Given this list of marker genes Prmt2, Gramd1a, Foxp3, Smad2, Irgm1, Atp4b, Cflar, Mup11, Mir182, Nos3, Abcb4, Bpi, Akap12, Xiap, Rarg, Trim12c, Ggt1, Map2k7, Fkrp, E2f1, Zfp747l1, Mir494, Defa22, Cd55b, Nfkbiz, Creb1, Aacs, Asns, Fas, Selenos, Fbxo3, F2r, Mir223, Defa26, Tgfbr2, Spp1, B2m, Cbl, Il10ra, Cyp26b1, Kdm6a, Mbd3, Trem2, Selenow, Wbp2, Slit3, Snhg20, Pik3ca, Pdcd1lg2, Scnn1a, Mup3, Esr2, Insig2, Mir181a-2, Dnm1l, Mir15a, Thbd, Ces1a, Scgb1a1, Pou4f1, Kdm3a, Abca1, Ppard (peroxisome proliferator activator receptor delta), Crebrf, Bdnf, Gpr83, Mir30d, Il36a, Defa3, Mir98, Brca1, Nfkbib, Safb, Mir125a, Pck1, Sphk2, Cebpb, Slco1b2, Skp2, Mir26a-1, Ccl19, Ass1, Zfp747, Fosl1, Pdcd4, Pak1, Fech, Zmiz1, Ifng, Erbin, Ptger4, Tnip2, Aldh1a2, Tead2, Ticam1, Trim5 (NCBI Gene Id 675296), Aqp1, Rhox13, Per1, Mef2c, Prkce, Ptgdr, Cdo1 (NCBI Gene Id 76278), Bmp4, Cd6, Mest (mesoderm specific transcript), Meiosin, Acer2, Fkbp4, Ccl21a, Ret, Parp1, Rpl27, Xrcc5, Lta, Agl, Slc12a3, T, Ppp1r9b, Kank2, Prpf8, Adcy5, Gba1, Plcg2 (NCBI Gene Id 234779), Tnfrsf11a, Slpi, Plaa, Osr1, Areg, Bmp6 (NCBI Gene Id 28108), Lep, Ucp2, Mif, Hmgb2, Trim63, Bad, Acsbg1, Sox30, Cyp27b1, Rnf4, Bcl2, Mdm2, Pparg, Ptger2, Ptgds, Lcor, Slc11a1, Adcy1 (adenylate cyclase 1), Mir26b, Ltf, Serpinf1, Cxcl15, Gbp6, Zfp366, Irak4, Gata2, Card9, Clock, Avp, Sva, Ang4 (NCBI Gene Id 328486), Abca3, Csf3, Brinp1, Axin2, Alad, Srarp, Hmga2, Nr2f2, Nfkb2, Acta1, Pdk4, Epha3, Bin1, Stap1, Aldh3a1, Brinp2, Cnp, Adcy3, Cfh, Mir511, Mapk1, Ptch1, Mn1, Ren1, Drd2, Tpcn2 (NCBI Gene Id 233979), Prkcb, Hes1, Ugt1a6b, Elk1, Map4k1 (mitogen-activated protein kinase kinase kinase kinase 1), Tnfaip3, Foxo1, Mir199a-1, Mbp, Irs1, Scn11a (NCBI Gene Id 24046), Add1, Mir467d, Arid1a, Uba5, Ube3a, Cdc73, Ptafr, Ccl27a, Calcr, Ccl19-ps3, Noct, Tnfrsf1b, Alox12 (NCBI Gene Id 11684), Pten, Tacr1, Cdkn1b (cyclin dependent kinase inhibitor 1B), Tbxas1, Lefty1, Scimp, Pdcd7, Gprin3, Igfbp2, Plscr3, Hoxb13, P2ry4, Mgst1, Ddit4, Arid5a, Selenof, Got1, Fbp1, Rps6ka3, Ezh2, Abcb1a, Gramd1b, Synj1, Ccl19-ps4, Mapk8, Fam210b, Mir107, S100a8 (NCBI Gene Id 99591), Phb2, Mir672, Irak1, Trim55, Gjb6 (NCBI Gene Id 52881), Cyp7a1, Mir24-1 (NCBI Gene Id 387184), Nr1h4, Cxcl2, Gstcd, Bcl10, Mir202, Shq1, Hand2, Stc1, Vdr, Abr, Esrrg, Mup5, Irf3, Igkj1, Zbtb7a, Gnas, Alas1, Ccdc62, Slc39a9, Abl1, Socs2, Gnrh1, Postn, Gsk3b, Atp1a2, Cpn1, Cxcl10, Ptgir, Tnfsf4, Nr1h3, Pik3r1, Ly96 (NCBI Gene Id 17087), Ptges3, Hspa8, Mir184, Trim30a, Cdk19, Safb2, Tlr9, Pou5f1, Ctsl, Gfer, Ddx17, Acod1, Ptgfr, Hoxd13, Il1b, Irak3, C2, Tnip3, Git1, Rnf14, Mir381, Mgarp, Th, Kl, Mpo, Npas4, Mir7-2, Tlr4, Bdkrb1, Rest, Bckdhb, Otud5, Sox10, Lats1, Jund, Hoxa13, Efnb2, Cited1, Sst, Ltk, Tab2, Mup2 (major urinary protein 2), Defa29, Mir181b-2, Sstr3, Lias, Sult1a1, Hnrnpd, Bcr, Gpr155, Gjb2, Atp5f1a, Tlr2, Tfap2a, Ccl19-ps1, Ces1f, Mir7-1, Ovca2, Adam17, Yes1, Pax2, Havcr1, Cx3cr1, A2m, Ar, Adm, Mir142, Sirpa, mt-Nd3, Mapk14, Htr5a, Ffar3, Defa30, Aard, Ptk6, Lbp, Nr2c2, Adam15, Stat5b, Cry2, Crls1, Cdkn2d, Smarca4, Esrrb, Tbx2, Cad, Scd4, Ntrk2, Maob, Cd180, Mir30c-2, Ccl21d, Wnt7a, Sgk1, Ednrb, Cyp19a1, Adra1b, Nfkbil1, Nlrc3, Map7, Cnot3, Gabrb1, Brinp3, Dnmt3a, Tie1, Oxt, Dnaaf2, Gdap2, Ces1g, Rplp0, Hnrnpu, Blvra, Il12a, Epha5, Lmo3 (NCBI Gene Id 16910), Triml2, Klf9, Sprr2c-ps, Mtdh, Il12rb2, Spi1, Gdnf, Scgb2a2 (NCBI Gene Id 102639117), Ogt, Scnn1b, Abcc1, Ptgs2, Cldn1, Cxcl16 (NCBI Gene Id 66102), Pim1, Clk2, AY761185, Mir26a-2, Spon2, Cyp1b1, Abcg1, Trip4, Plscr2, Rora, Ido1, Cav3, Abl2, Ihh, Ly86, Cd68, Akr1c13, Rock2, Slc6a4, Gstp1, Extl3, Junb, Ccl2, Ugt1a1, Mapk3, Ppbp (pro-platelet basic protein), Trpv4, Sod2 (superoxide dismutase 2, mitochondrial), Trim12a, Klf4, Mir140, Wnt5a, Defa37, Shpk, Tyms, Irf8, Gbp2, Gnpat, Gja1 (gap junction protein, alpha 1), Nr0b1, Usp26, Nkx3-1, Mir345, Mir323, Nod2, Xbp1, Smo, Fgf23 (fibroblast growth factor 23), Strn3, Mir23b, Umod, Wdr83, Mir486, Gh, Cnot2, Gbp2b, Gata1, Fosl2, Cmpk2, Sprr2f, Map2k1, Mgst2, Aqp3, Lbh, Ntsr1, Etnppl, Mir181c, Pde4b, Slc12a2, Ccl19-ps6, Atp1a1, Adamts13, Igtp, Mup1, Npc1, Bmp7, Ildr1, Il12b, Oxtr (NCBI Gene Id 18430), Ncor1, Tek, Camp, Nlrp3, Ptk2b, Anxa1, Cryab, Sstr5, Cd300lb, Cnot1, Irak2, Fmo1, Upf1, Apoa4, Mir409, Tspo, Phb1, Mir30c-1, Zfp36, Vps11, Ldoc1, Zfp703, Ccl21e (C-C motif chemokine ligand 21E), Edn1, Slc5a5, Ucp1, Rps6kb1, Cpt1a, Ctnnb1, EU599041, Hdac8, Ffar2, Ccl19-ps5, Tmf1, Acp5, Mir16-2, Stk39, Mir3099, Sstr2, Trim30c, Acsl1, Hnrnpk, Psph, Mirlet7g, Calr (calreticulin), Tyr, Sprr2e, Bche, Ahr, Asxl1, Reg3g, Id3, Slc10a3, Gata4, Fbxo32, Defa5, Mir431, Med1 (mediator complex subunit 1), Ppara, Prkaa2, Tirap, Ptger3, Cd84, Csnk2a1, Comt, Errfi1, Trerf1, Msn, Rara, Sprr2g (NCBI Gene Id 20761), Lpl, Ctsg, Gpx1, Prkaa1, Pax6, Kcnmb1, Mmp2, Capn2, Adam9, Dag1, Rgs9, Trim6, Mir210, Nr3c2, Bmal1, Nfe2l1, Glb1, Esrra (estrogen related receptor, alpha), Pf4, Cxcl13, Myog, Srr, Kcnj11, Hadhb, Defa35 (NCBI Gene Id 100041688), Mir425, Ldlr, Dab2ip, Casp9, Kdm5d, Ephb2, Endog, Cd86, Epo, Tmem161a, Pcsk1, Syk, Rorb, Akap13, Lyn, Tescl, Foxh1, Mir342, Hoxa10, Ankk1, Phc1, Ccl28, Kmt2d, Inhbb, Mir139, Mrc1, Scd3, Plscr1, Rpl36al, Casp3, Ccr7, Fam107a, S100a14, Col6a1, Taf7, Cat, Gfi1, Hnmt, Cav1, Ghsr, Cldn4, Cxcl5, Akirin2, Foxa1, Tut4, Ccr5, Fer, Pcna, Mir27a, Hpgd, Fshr, Pias2, Akt1, Cr2, Gbp10, Ptpn6, Tjp1, Pycard, Sox2, Nr4a1, Avpr1a (arginine vasopressin receptor 1A), Lcat, Idh1, Akr1c12, Ppm1e (protein phosphatase 1E (PP2C domain containing)), Star, Acr, Mir598, Mapk15, Mup4, Crh, Ncoa1, Palm3, Fes, Esr1, Acaca, Ugt1a6a, Cd80, Mir193a, Mmp15, Wfdc21, Scd1, Rela, Ednra (NCBI Gene Id 14737), Pdk3, Pgr, Serpine1, Adcy6, Ucp3, Gpbar1, Trim25, Heyl, Mir501, Stxbp1, Nedd4, Tnip1, Nr3c1, Rnf6 (NCBI Gene Id 74132), Smyd3, Tead1, Pln, Casp7, Pdgfrb, Hoxa11, Rorc, Padi2, Mecp2, Hnrnpa0, Mmp8, Gsk3a, Alpl, Txnip, Abhd2, Fos, Il18, Scamp3, Ddrgk1, Abca2, Rhoa, Ncor2, Runx1, Btk, Agtr1b, Mlc1, Lpar1, Pdia3 (NCBI Gene Id 18794), Mir21a, Bcl2l2, Fcgr4, Tgfb3, Aanat, Slc7a5, Pitx2, Ufsp2, Mir205, Dnaja1, Pde2a, Trim30d, Rxrg, Nkx2-1, Hmox1, F7, Ddx5, Htr7, Aicda, Sfrp1 (NCBI Gene Id 72362), Por, Ces1d (carboxylesterase 1D), Ikbip, Mir224, Snw1, Rbbp7, Tgfb1, Jun, Il36b, Csn1s1, Lancl2, Lilrb4a (leukocyte immunoglobulin-like receptor, subfamily B, member 4A), Raet1d, Pagr1a, Slco1a1, Gip, Adipoq, Srebf1, Mir350, Defa39, Cx3cl1, Mir155, Tcf21, Ncoa3, Ruvbl2, Gdap1, Smarcd1, Nos2, Dynap, Agtr1a, Gpx4, Paqr7, Cd55, Snai2, Tnc, Dsg2, Plcb1, Aifm1, Kat5, Nfkbia, Ncf2, Zfp36l1, Adh5, Tgfbr1, Mir146b, Il1rn, Tfrc, Dnaaf4, Tbxa2r, Ces1c, Hoxa2, Hsf1, Mir29b-2, Gbp5, Prdm2, Cftr, Pde4d, Sirt1 (NCBI Gene Id 93759), Lrp6, Cnr2, P2rx7, Ptk7, Tnf, Lrat, Rwdd1, Pmvk, Mir146, Dusp10, Hmgb1, Notch1, Ucn3, Sstr4, Cd96, Eif4e, Lcn10, Ccl21f, Lox, Tesc, Ncl, Tacr3 (tachykinin receptor 3), Atm, Lgals9, Mir7b, Ptpn22, Pabpn1, Defa23, Hoxa9, Lrp8, Nrip1, Nkx2-2, Elane (elastase, neutrophil expressed), Gch1, Irgm2, Ptger1, Pou4f2, Trim30b, Pck2, Adipor2, Defa25, Sdc1, Insig1, Ubr5, Chmp5 (charged multivesicular body protein 5), Adcy2, Casp4, Ifnar1, Trim68, Uts2, Htr1b, Ptpn11, Stc2, Inhba, Ghr, Ffar1, Defa31, Defa42, Cnr1, Fasl, Havcr2, Jak2 (NCBI Gene Id 98155), Krt13, Tifab, Epsti1 (epithelial stromal interaction 1), Bola3, Scarb1, Ccl3, Paqr8, Park7, Src, Rpl13a, Akap8, Cybb, Mir484, Peli1, Adh1, Mir150, Cd274, Nodal (nodal growth differentiation factor), Vps18, Mir217, Penk, Egfr, Gramd1c, Ccna2 (cyclin A2), Nfkb1, Isl1, Zdhhc7, Cps1, Sbno2, Klrk1, Prkd1, Cyp1a1, Plscr4, Vps4b, Pde3a, Prdx3, Hdac6, Daxx, Ndufa13 (NCBI Gene Id 67184), Gpld1, Naglu, Nefl, Efna5, Msx2, Myd88, Itga2, Nanog, Mapkapk2, Gria1, Dkk1, Crhbp, Srd5a2, Fgf10, Cry1, Casr, Fdx1, Defa38, Rbp1, Cyp26a1, Pdx1, Ripk2, Stat3, Pid1, Defa40, Tbl1x, Dab2, Pfkfb1, Mir383, Axl, Calcoco1, Ces1b, Vim, Ctr9, Sstr1, Il17a, Scd2, Letmd1, Defb1, Il1f10, Tat, Cactin, Ctsh, Defa21, Yy1, Cd14, Defb21, Ep300, Defa28, Agxt, Anxa3, Traf6, Mir147, Ppargc1b, Trib1, Mirlet7a-2, Ranbp1 (RAN binding protein 1), Scnn1g, Sgms1, Akr1c18, Cd38, Gad2 (glutamic acid decarboxylase 2), Sash1, Gpi1, Il1a, Mir194-1, Hrh3, Ncoa2, Defa2, Cacna1b, Halr1, Mapkapk3, Smad6, Rxrb, Sp100, Mettl21c, Tgfb2, Il36rn, Malt1, Ube2l3, Tbx1, Ghrhr, Defa41, Fosb, Stra8 (stimulated by retinoic acid gene 8), Rbp4, Tgfbr3, Mir30b, Eif2ak2, Adcy8, Dgat2, Snca, Nfatc4, Trim24, Cxcl9, Yap1, Zfp764, Nr1d1, Kcnk4, Mir29a, Eif4ebp1, Hsd11b2, Il10, Uri1, Gipr, Zfp36l2, Il36g, Car9, Ttc39aos1, Carm1, Ankrd1, Grip1, Rbfox2, Sox9, Defa20, Hoxa1, Gjb3, Sprr2a1, Kif18a, Prkca, Ramp3, Hmgcs2, Rac1, Nuggc, Lipa, Prdx2, Cst11, Dynapl1, Cdkn1a, Vps54, Foxo3, Sprr2d, Hdac1, Ascl1, Hsd17b2, Tcf3 (NCBI Gene Id 21423), Cd36, Mir293, Il23r, Agtr2, Oaz1, Ptpru, Kmo, Defa34, Cyp24a1, Ces1h, Ufl1, Ticam2, Igf2r, Pappa, Ppp5c, Mir200c, Mir10a, Ufm1, Ogg1, Defa24, Ccl21b, Stat1, Defa17, Akr1c19 (NCBI Gene Id 76349), Col1a1, Trp63 (transformation related protein 63), Htra2, Foxp1, Cyp7b1, Paf1, Mir29b-1, Mir433, Acaa1a, Gldc, Slc2a2, Trh, Phex, Mir500, Twf2, Mir24-2, Mir194-2, Kcnk2, Cdk4, Ywhah, Sprr2b, Myod1, Stk11, Rxra, Ucn, Ace, Dhh, Mir181a-1, Adcyap1, Litaf, Or51e2, Trim41, Cebpe, Kdm4c (lysine (K)-specific demethylase 4C), Kcnj8 (potassium inwardly-rectifying channel, subfamily J, member 8), Zc3h12a, Osbpl7, Nqo1, Tfpi, Mbd2, Serpina7, P2ry6, Grn, Gkn2, Zfp683, Cnot9, Mir199a-2, Map1b, Mstn, Map2k3 (mitogen-activated protein kinase kinase 3), Dgkq, Ifnb1, H2az1, Igf1, Nos1, Gata6, Suz12, Casp1, Gnai1, Ces1e, Bmi1, Zfp764l1, Btg2, Il6, Gbp3, Gper1 (NCBI Gene Id 76854), here is a description of the gene set: species: Mus musculus Any process that results in a change in state or activity of a cell or an organism (in terms of movement, secretion, enzyme production, gene expression, etc.) as a result of a lipid stimulus. Mouse Gene Set: GOBP_RESPONSE_TO_LIPID